The following is a description of a gene set: Paracetamol ADME species: Mus musculus Mouse Gene Set: REACTOME_PARACETAMOL_ADME, and this is the list of marker genes: Nat2, Sult1e1, Abcc5, Nat3 (N-acetyltransferase 3), Abcc1, Abcc2, Ugt2b36, Gstt1, Ugt2b34, Ugt1a1, Ugt1a8, Sult2a1, Nat1, Ggt1, Ugt1a7c, Ggt7, Acy1, Cndp2, Gstp1, Ggt5, Ugt1a6a, Abcc3, Ugt2b35, Ugt1a9, Abcc4, Gstp2, Cyp2e1, Ggt6, Sult2a2, Ugt2b5, Ugt2b37, Sult1a1, Ugt2b1, Gstm2, Ugt2b38